Given this list of marker genes TRAF5, TNFRSF1A, TNF, CASP3, FADD, TRAF2, TRADD, RIPK1, CASP7, CASP8, here is a description of the gene set: Pathway Definition from KEGG: TNF -> TNFRSF1A -> (RIPK1+TRADD+TRAF2/5) -> FADD -> CASP8 -> (CASP3,CASP7) species: Homo sapiens Extrinsic apoptotic pathway. Pathway ID: N00145. Pathway type: Reference. Pathway class: nt06516 TNF signaling. Human Gene Set: KEGG_MEDICUS_REFERENCE_EXTRINSIC_APOPTOTIC_PATHWAY